The following is a description of a gene set: Any process that stops, prevents, or reduces the frequency, rate or extent of the directed movement of ions from one side of a membrane to the other. Mouse Gene Set: GOBP_NEGATIVE_REGULATION_OF_MONOATOMIC_ION_TRANSMEMBRANE_TRANSPORT studied in species Mus musculus, and this is the list of marker genes: Atp1a2, Kcne1, Kcne5, Rgs4, Nos1, Pkd2, Sestd1, Nherf1, Ptger3, Stk39, Rem1, Kel, Mrln, Ywhae, Gsto1, Fmr1, Ucp2, Kcnab1, Oxsr1, Drd2, Ppp3r2, Ahr (aryl-hydrocarbon receptor), Sln, Osr1, Trdn, Agrn, Commd1, 1810037I17Rik, Hamp, Gpr35, Cbarp, Slc26a5 (solute carrier family 26, member 5), Mmp9, Sumo1, Mcub, Ubqln1, Nedd4, Pik3c2a, Ywhaq, Prkce, Smim6, Gstm7, Tgfb2, Calm1, Grp, Dysf, Iscu, Kcne2, Camk2d, Bcl2 (NCBI Gene Id 98734), Calm3, Pcsk9, Atp7a, Vdac1, Ppp3cb, Ppp3ca, Pln, Ubr3, Tlr9, Nedd4l, Ntsr1, Actn2, Epo, Tmbim6, Fbxo11, Hamp2, Fcrl5, Sri, Zfas1, Fkbp1b, Ank3, Kcnh2, Bin1, Tgfb1, Calm2, Slc30a1, Ppif, Casq2, Kcnrg, Gnb5, Akt1, Ppp3cc, Crbn, Drd4, Mtor, Kcnq1, Gopc, Cav3, Ppp3r1, Cacna1f, Kcne3, Cav1